Given this list of marker genes VLDLR, IHH (Indian hedgehog signaling molecule), PCSK9, TREM2, PLTP, here is a description of the gene set: species: Homo sapiens Binding to a very-low-density lipoprotein particle, a triglyceride-rich lipoprotein particle that is typically composed of APOB100, APOE and APOCs and has a density of about 1.006 g/ml and a diameter of between 20-80 nm. Human Gene Set: GOMF_VERY_LOW_DENSITY_LIPOPROTEIN_PARTICLE_BINDING